Given this list of marker genes Cyp1a2, here is a description of the gene set: Reactome Pathway: Aromatic amines can be N-hydroxylated or N-dealkylated by CYP1A2 electronically inferred by orthology from the curated human pathway part of: Xenobiotics studied in species Mus musculus This event has been computationally inferred from an event that has been demonstrated in another species.<p>The inference is based on the homology mapping from PANTHER. Briefly, reactions for which all involved PhysicalEntities (in input, output and catalyst) have a mapped orthologue/paralogue (for complexes at least 75% of components must have a mapping) are inferred to the other species.